The following is a description of a gene set: studied in species Homo sapiens The gene expression program underlying the specification of human cell types is of fundamental interest. The study authors generated human cell atlases of gene expression and chromatin accessibility in fetal tissues. For gene expression, the study authors applied three-level combinatorial indexing to >110 samples representing 15 organs, ultimately profiling ~4 million single cells. The study authors leveraged the literature and other atlases to identify and annotate hundreds of cell types and subtypes, both within and across tissues. Our analyses focused on organ-specific specializations of broadly distributed cell types (such as blood, endothelial, and epithelial), sites of fetal erythropoiesis (which notably included the adrenal gland), and integration with mouse developmental atlases (such as conserved specification of blood cells). These data represent a rich resource for the exploration of in vivo human gene expression in diverse tissues and cell types. from publication Cao J, O'Day DR, Pliner HA, Kingsley PD, Deng M, Daza RM, Zager MA, Aldinger KA, Blecher-Gonen R, Zhang F, Spielmann M, Palis J, Doherty D, Steemers FJ, Glass IA, Trapnell C, Shendure J (PMID 33184181) Human Gene Set: DESCARTES_FETAL_INTESTINE_STROMAL_CELLS Marker genes curated from the annotated cluster as represented in the Descartes Human Gene Expression During Development database., and this is the list of marker genes: ADAMTS14, COL6A5, FNDC1-IT1 (NCBI Gene Id 100874312), MSC-AS1, EDAR, OR7E47P, SYNDIG1, PRR16, ITGA11, CH25H, FNDC1, CCL19, TMEM119, LINC01082, FZD10, BMP5, TCF21, LUM, MUSK, F2RL2, ENSG00000250378, LPAR4, FNDC1-AS1, CXCL14, LINC03007, FBLN1, MMP27, DPT, SHISA3, PDGFRB, NXPH1, ADH1B, SP5, ADRA1A, MSC, GABRG3, LRP4 (NCBI Gene Id 4038), NPY, PDGFRA, SPON2, GLI1